Given this list of marker genes MEG3, SLC7A11, ACTA2, PRSS23, UCHL1, P2RX4, RGS1, TFPI, DDAH2, TUSC3, NQO1, SORT1, TGFBR2, FZD7, RGS2, HLF, HOMER3, SENP7, RIPOR2, RHOC, KIF3C, ERG (ETS transcription factor ERG), SMARCA1, FSTL1, HOXA5, IL1RL1, IFI16, GDF3, HBP1, ALDH1A1, ANXA2, NRCAM, IRF9, AHR, BAMBI, HPGDS, FXR1, TRIB2, ARID5B, ID1, WSB1, NEDD9, COL3A1, ZBTB20, RBPMS, CXCL8, C8orf17, H2BC12, SERTAD3, SLC35G2, RSRP1, NTS, SERPINB9, MARK4, BNIP3L, H1-0, CD69, EVI2A, ARMCX2, GSTM4, PDLIM5, RGS13, SPARC, GLMN, VCAN, ZFYVE16, DNAJB5, ENC1, TCN1, ALDH1A2, TOM1L1, TRIM5, CDC42EP3, COCH, DRAM1, HMOX1, SPTBN1, PRKAR1A, RAB33A, CEACAM1, RPL35A, IL17RB, ABI2, TCF7L2, TCP10L, S1PR1, JUP, ODF2, SLC2A3, SOX4, SERPINB2, APOE, NLRP1, PALLD, AMIGO2, PROCR, RNF17, PSG9, ARHGEF12, TWF1 (NCBI Gene Id 82712), TUBA1A, RPS6KA5, F2RL1, EMP1, TM4SF1, SLC39A9, DEPTOR, CYP1A1, CCNG2, TMEM176B, OPTN, NTRK3, TNFSF4, KLHL24, TOX, RB1, CRHBP, MFAP2, NPTX1, DUSP6, SLC35D2, ADD3, DAB2, CA2, RRAS, CALCRL, CLEC2B, MALL (mal, T cell differentiation protein like), GBP2, FAR2, CEP162, IL13RA1, STX6, PPFIBP1, GPR32, KLF6, RUNX1, QPRT, DDR1, HSPB1, FBXW11, NCAN, NFKB2, RIGI, EPS8, SOCS2, CREM, MIR22HG, GDF15, NAP1L1, THSD7A, E2F5, PLAT, LPAR6, LILRA2, ARG2, DGKE, MXI1, TGFB1I1, SEPTIN10, MAGED2, WFDC1, IRF7, PNRC1, PDE4B (phosphodiesterase 4B), AGTR1, PLCG1, HOXB6, UBL3, GUCY1A1, ZDHHC17, ECM1, ZNF217, NID1 (nidogen 1), CH25H, BBIP1, FNBP1L, CD226, CD200, GSN, PDCD4, TAAR2, SAMSN1, ANK3, TXNIP, here is a description of the gene set: species: Homo sapiens Human Gene Set: TONKS_TARGETS_OF_RUNX1_RUNX1T1_FUSION_HSC_UP The t(8;21)(q22;q22) occurs frequently in acute myelogenous leukaemia and gives rise to the transcription factor fusion protein, RUNX1-RUNX1T1 (also known as AML1-ETO). To identify the genes dysregulated by the aberrant transcriptional activity of RUNX1-RUNX1T1, we used microarrays to determine the effect of this mutation on gene expression in human progenitor cells and during subsequent development. Gene signatures of these developmental subsets were very dissimilar indicating that effects of RUNX1-RUNX1T1 are highly context dependent. We focused on gene changes associated with the granulocytic lineage and identified a clinically relevant subset of these by comparison with 235 leukaemia patient transcriptional signatures. We confirmed the overexpression of a number of significant genes (Sox4, IL-17BR, CD200 and gamma-catenin). Further, we show that overexpression of CD200 and gamma-catenin is also associated with the inv(16) abnormality which like RUNX1-RUNX1T1 disrupts core binding factor activity. We investigated the functional significance of CD200 and gamma-catenin overexpression in normal human progenitor cells. The effect of IL17 on growth was also assessed. Individually, none of these changes were sufficient to recapitulate the effects of RUNX1-RUNX1T1 on normal development. These data provide the most comprehensive and pertinent assessment of the effect of RUNX1-RUNX1T1 on gene expression and demonstrate the highly context-dependent effects of this fusion gene. from publication Tonks A, Pearn L, Musson M, Gilkes A, Mills KI, Burnett AK, Darley RL (PMID 17898786) Genes up-regulated in normal hematopoietic progenitors by RUNX1-RUNX1T1 fusion.